Given this list of marker genes CCL27, MKNK1, ARRB1, MAP3K10, IL17RD, CCL8, MAP3K11, UNC119, CCL26 (C-C motif chemokine ligand 26), RAB4B, MAP2K2, MUC5B, CDC42, PFKFB4, MAP4K1, SPRY4, MAPK8IP1, here is a description of the gene set: Our objective was to establish an experimental model of a self-sustained and bistable extracellular signal-regulated kinase 1/2 (ERK1/2) signaling process. A single stimulation of cells with cytokines causes rapid ERK1/2 activation, which returns to baseline in 4 h. Repeated stimulation leads to sustained activation of ERK1/2 but not Jun N-terminal protein kinase (JNK), p38, or STAT6. The ERK1/2 activation lasts for 3 to 7 days and depends upon a positive-feedback mechanism involving Sprouty 2. Overexpression of Sprouty 2 induces, and its genetic deletion abrogates, ERK1/2 bistability. Sprouty 2 directly activates Fyn kinase, which then induces ERK1/2 activation. A genome-wide microarray analysis shows that the bistable phospho-ERK1/2 (pERK1/2) does not induce a high level of gene transcription. This is due to its nuclear exclusion and compartmentalization to Rab5+ endosomes. Cells with sustained endosomal pERK1/2 manifest resistance against growth factor withdrawal-induced cell death. They are primed for heightened cytokine production. Epithelial cells from cases of human asthma and from a mouse model of chronic asthma manifest increased pERK1/2, which is associated with Rab5+ endosomes. The increase in pERK1/2 was associated with a simultaneous increase in Sprouty 2 expression in these tissues. Thus, we have developed a cellular model of sustained ERK1/2 activation, which may provide a mechanistic understanding of self-sustained biological processes in chronic illnesses such as asthma. Human Gene Set: LIU_IL13_MEMORY_MODEL_UP from publication Liu W, Tundwal K, Liang Q, Goplen N, Rozario S, Quayum N, Gorska M, Wenzel S, Balzar S, Alam R (PMID 20123980) species: Homo sapiens Genes up-regulated in BEAS-2B cells (bronchial epithelium) stimulated with IL13 on days 1 to 3 and then rested for the next 3 days (repeated-stimulation or memory model)